The following is a description of a gene set: Human Gene Set: KEGG_MEDICUS_REFERENCE_TRH_TRHR_PLCB_PKC_SIGNALING_PATHWAY Pathway Definition from KEGG: TRH -> TRHR -> GNAQ/11 -> PLCB -> (Ca2+,DAG) -> PKC -> TSHB TRH-TRHR-PLCB-PKC signaling pathway. Pathway ID: N00918. Pathway type: Reference. Pathway class: nt06322 TRH-TSH-TH signaling. studied in species Homo sapiens, and this is the list of marker genes: GNAQ, PRKCA, PLCB1, PLCB2, PLCB4, TRHR (thyrotropin releasing hormone receptor), TRH, PLCB3, TSHB, PRKCG, GNA11 (G protein subunit alpha 11), PRKCB